The following is a description of a gene set: Leukoencephalopathy that gets more severe with time. species: Homo sapiens Progressive leukoencephalopathy Human Gene Set: HP_PROGRESSIVE_LEUKOENCEPHALOPATHY, and this is the list of marker genes: AARS2, COA8, KIF5A, SDHA, PLAA